Given this list of marker genes CELSR2, PGBD2, HOXD13, SLC10A7, LRIF1, DARS2, AMD1, LARS1, KDM5A, TIMM23B, PHF3, SRD5A2, ABCC2, RPL34, PDE5A, DPYSL2, HCCS, API5, CD28, BCL6, ATP2C1, ZFAND6, OSBPL11, GPATCH11, STIM2, TFDP1, CCPG1, UBE2W, ZBTB24, CHMP5, PLOD2, PYGO1, PYROXD1, CSRP1, TMT1A, LAPTM4A, CHD2 (chromodomain helicase DNA binding protein 2), CGN, TMEM183A, WDR82, CHERP, AADACL3, FAM204A, PHF6, XPO4, ZRANB1, ABHD18, AKTIP, CHRAC1 (chromatin accessibility complex subunit 1), EDEM3, IPO7, DIO1, SUDS3, UCHL5, TMEM248, BCLAF1, CTNNBIP1, MARCHF6, ABCD3, ARMCX2, CDH13, MEX3B, VSIG10, DAZAP2, PRTG, FAM168B, NFYB, TMEM260, SET, LASP1, ZMYM4, MOXD1, CACNB2, CCNL2, CHSY1, GABRA4, ANKIB1, CYRIB, RBPJ, RPIA, SCN2A, ELAVL2, MT1M, FAN1, DNAAF4, CDK8, CASTOR1, MED13, FAM118B, C17orf58, SIM1, WEE1, MAP3K7, FRS2, PRXL2A, PPP2R5A, MAGI1, ATXN7, CHD6, COL4A1, CD200, CCL13, PLEKHG4, SGCB, FRK, MREG, LSM12, TMPRSS11F, SCAI, TMEM168, HRH4, TM9SF2, CORO1C, PIK3CD, SMAP1, CPEB2, IMMP1L, MYO1B, SLC26A9, RNF182, NWD2, RNF213, RFTN2, C8A, C4orf46, TRIM10 (NCBI Gene Id 95309), ATP9A, PLGRKT, KDM6A, LRRC40, ZFP28, SFRP2, PTPRB, NACC2 (NCBI Gene Id 138151), NRIP1, GDI2, FGF18 (NCBI Gene Id 8817), PRR5L, ANO9, GPR55, VSTM4, TNKS2, DDX17, LCOR, DCUN1D3, TNC, PFKFB2, GGA3, MYPOP, SLMAP, ATAD2B, ABHD5, CNTN2, H3-3B, NEDD4L, COX7A2, CIBAR1, MED23, ARK2N, PIAS1 (NCBI Gene Id 8695), GTF2A1, LHX1, ARHGAP21, MLF2, GPR15 (NCBI Gene Id 2838), RLF, CYRIA, SOS2, SLC31A1, OCLN, DSG2, PTK2B, RGPD4, RGS6, MDM2, EHF, ZNF860, LOX, ST6GALNAC4, INHBC, here is a description of the gene set: Human Gene Set: MIR224_5P species: Homo sapiens Genes predicted to be targets of miRBase v22 microRNA hsa-miR-224-5p in miRDB v6.0 with MirTarget v4 prediction scores > 80 (high confidence targets). from publication Chen Y, Wang X (PMID 31504780)